The following is a description of a gene set: Mouse Gene Set: WP_GPCRS_CLASS_B_SECRETINLIKE species: Mus musculus GPCRs, class B secretin-like, and this is the list of marker genes: Adgre5, Gipr, Sctr, Adcyap1r1, Adgrl4, Crhr2, Adgrg2, Adgre1, Adgrl1, Glp2r, Pth1r, Crhr1, Adgrl3, Glp1r, Calcrl (calcitonin receptor-like), Ghrhr, Vipr1, Vipr2, Pth2r (NCBI Gene Id 213527), Calcr, Adgrl2, Gcgr